Given this list of marker genes PHIP, ELOVL4, PTPRG, COL24A1, GLI3, HAPLN1 (hyaluronan and proteoglycan link protein 1), SLC24A3, GPR107, UBE2Q2, SMC2, RASAL1, CD28, SLC7A11, CYRIB, INO80, CNTN1, RAB3C, WDR44, C1QTNF8, DMAC1, SETD9, DDX3X, GAB3, FAF2, PTCRA, RIF1, CYRIA, PPP1R3G, CXXC4, ADORA2A, PPP1R12A, ZFP36L1, SYT1, LARP6, BCL2L12, PRICKLE4, KDM1A, FBXO38, ARPC5, FAM210A, GLIPR1L2, TMEM238, SLC25A30, RGS18, TAF12, ZMYND12, SREK1IP1, MAP3K21, HNRNPDL, MAP1A, KAZN, GEMIN8, ABCA8, GRM1 (NCBI Gene Id 2911), CACNA2D3, CACHD1, TRAPPC8, ASGR2, PGAP4, TREML1, SORL1, ADAMTS18, ASXL2, XCL2, IL17RE, XCL1, MMP12, NFAT5, CSN2, NF1, OSBPL1A, ABHD12, GPATCH2L (G-patch domain containing 2 like), SPRED3, TRIM66, TMEM150C, ADIPOR2, ASXL3, PASK, RIBC1 (NCBI Gene Id 158787), ACAN, PTPDC1, NEK2, FBXO42, TRIM39, NCK1, GTF2I, CAPZB, RRN3, PPP6R1 (NCBI Gene Id 22870), CALCR, RPA1, FRAS1, SAP30L, MATN3, EXOSC2, IRF6, CALM3, AK4, SEMA4G, ELAVL2, INSIG2, CSF2RB, CTDSP1, PWWP2A, SLC8A2, ENPP6, ZIC3, here is a description of the gene set: Human Gene Set: MIR4264 studied in species Homo sapiens from publication Chen Y, Wang X (PMID 31504780) Genes predicted to be targets of miRBase v22 microRNA hsa-miR-4264 in miRDB v6.0 with MirTarget v4 prediction scores > 80 (high confidence targets).